The following is a description of a gene set: The proteolytic processing of an inactive enzyme to an active form. Mouse Gene Set: GOBP_ZYMOGEN_ACTIVATION studied in species Mus musculus, and this is the list of marker genes: Klkb1, Fga, Klk1b11, Apoh, Dhcr24, Serpine2 (serine (or cysteine) peptidase inhibitor, clade E, member 2), Ctsl, Cuzd1, F9, Clec3b, Prss12, Klk1b1, Prss3b, Tmprss9, Eno1, H2bc1, Klk1b16, F11, Furin, Serpine1, Hgfac, Klk1b26, Plat, S100a10, Klk1, Ggt1, Hpn, Plgrkt, Eno1b, C1ra, Klk1b5, Ctsh, Klk1b9, Fgg, Klk1b24, C1rb, Anxa2, Mmp14, Klk1b8, Ctsz, Klk1b21, F12, Pgk1, Klk1b3, Serpinf2, Meltf, Plaur, Klk1b22, Thbs1, C1rl, Klk1b27, Hp, Vsir, Plau, Fgb, Klk1b4, Oma1, Cpb2